Given this list of marker genes Pira12, Pira2, Ms4a2, Pira13, Fcer1g, Lilra6, here is a description of the gene set: species: Mus musculus A protein complex composed of an Fc-epsilon RI alpha chain and an Fc-epsilon RI gamma chain dimer with or without an Fc-episilon RI beta chain and additional signaling components. The complex functions primarily as an activating receptor for IgE. Mouse Gene Set: GOCC_FC_EPSILON_RECEPTOR_I_COMPLEX